Given this list of marker genes CHRNB3, CHRNA5, CHRNA1, CHRNA10, CHRNB1, CHRNA7, CHRFAM7A, CHRNB2, CHRNB4, CHRND, CHRNA6 (cholinergic receptor nicotinic alpha 6 subunit), CHRNG (cholinergic receptor nicotinic gamma subunit), CHRNE, CHRNA9, CHRNA2, CHRNA4, CHRNA3, here is a description of the gene set: Selectively enables the transmembrane transfer of a cation by a channel that opens upon binding acetylcholine. Human Gene Set: GOMF_ACETYLCHOLINE_GATED_MONOATOMIC_CATION_SELECTIVE_CHANNEL_ACTIVITY studied in species Homo sapiens